Given this list of marker genes BCL10, RAB11FIP3, EXOC4, KASH5, BCL2L11, MARK4, KIF5B, NFS1, PQBP1, CEP76, HARBI1, TPGS1, CCDC15, TEKT1, KCNAB2, PIN4, CEP41, OVGP1, MARCKS, DNM3, SAXO4, CLMP, DLG1, EPS8L2, DCX (NCBI Gene Id 1641), HYLS1, RAB34, CFAP410, RIF1, DYNC1LI2, MICAL1, RPP25, TP53, GABRG3, CLIC4, EML5, MPHOSPH9, CALM3, PIK3R5, DYNLT5, KEAP1, HDAC3, DYNC1I2, LUZP1, PCM1, RPS6KA2, PACSIN2, NISCH, KIF2C, CDC7, FIRRM, REEP1, STRBP (NCBI Gene Id 55342), MAP1LC3C, TSKS, USP50, MVB12A, TUBGCP5, RASSF10, LRRK2, CEP78, PPP2CA, AK5, KIF11, GPSM2, DZIP1L, BMERB1, DUSP21, IPMK, DNAAF1, NFE2L2, TUBA8, CDC16, PDE4B, DCAF12, KAT2B, MAP7D3, SPRY2, GEM, TRAF3IP1, FAM184A, CCDC66 (NCBI Gene Id 285331), NPM1, TACC3, SMAD3, ZNF322, SNAP29, DYNC1LI1, PKHD1, TTBK1, CIMIP2C, PPP4R3B, NUDCD2, TTLL7, ATP2B4 (NCBI Gene Id 54594), AKNA, CFAP298, AXIN2, ANKS1B, FES, KATNB1, CHD3, RANBP9, CEP170B, CBX3, GNAI2, PIK3R4, TUBB3, RPS3, FNIP2, SORBS1, TAF1A, PJA2, CTNNBL1, EMD, MDM1, LRGUK, CHRM2, CEP57, RABL2B, DCTN2, LCK (LCK proto-oncogene, Src family tyrosine kinase, NCBI Gene Id 95387), TSC1, RITA1, KIF27, TNKS, HOXC8, PDCD6IP, ARHGEF10, TMEM67, KIF25, BOD1L2, RP2, CCDC141, AXDND1, EVC, MZT2A, FLCN, ZNF12, FNTA, NME8, TADA3, ABRAXAS2 (abraxas 2, BRISC complex subunit), DDHD2, CDC14A, PSMB5 (NCBI Gene Id 5693), TAOK1, NME3, CCDC13, SLC1A5, GAS2L3, CENPE, PLA2G6, CCDC61, DCLRE1B, PRKAR1A, CHMP1B, KIF3C, JADE1, MAPK1, NAV3, POLB (DNA polymerase beta), KIF26B, APC2, ALDOB, PBXIP1, CEP85L, CSPP1, INO80, NLRC3, TPPP, WASHC1, CDKN1B, PLK5, CCNO, PSEN2, ASAP1, RRAGD, AOX1, RIBC1, TERF1, FFAR4, RIBC2, CCDC57, MID1, CIAO1, DYNC2LI1, MIB1, LZTFL1, CCNE1, YTHDF2, TBC1D7, RABL6, DCTN6, BEX4, FCMR, CEP57L1, JTB, OFD1, TEX9, RASSF3, SDCCAG8, DZANK1, AGBL4, UHRF1, SELENOS, SLMAP (NCBI Gene Id 7871), HAUS1, CDC42BPG, KIF6, CEP126, CCT3, PRKCI, MIS12, SKA1, GTSE1, TEKT3, TBCCD1, STK3, RELL1, GLI2, UTRN, NUDC, UXT (ubiquitously expressed prefoldin like chaperone), PSMC4, GTF2F2, KIF18B (NCBI Gene Id 146909), CROCC, TFDP2, DNAH12, CD86, CTNND1, PLEKHA7, SAXO2, TTC28, PXN, RNF4 (NCBI Gene Id 6047), CD2AP, SERP1, FBXO5 (NCBI Gene Id 26271), CETN2, FAM234B, CAPG, MAPKAPK2, TPR, MKKS, HORMAD2, TUBB1, FMN2, BRCC3, IL4R, CCDC88C, CFAP95, CAMSAP2, CCT6A, PEA15, CROCC2, EZR, PDZD7 (NCBI Gene Id 79955), TOPORS, DVL1, RALBP1, ZFYVE19, CFAP107, ATXN7 (ataxin 7), GABARAPL1, FAM161A (NCBI Gene Id 84140), KIF21A, EML6, SPMIP6, CCND2, AGTPBP1, GPRC5C, CHMP1A, OCRL, TADA2A, MTUS1, CCDC178, CFAP100, SEPTIN10, MME, ASPM, SPDL1, SPMIP4, PRKAA1, KIF2B, HAUS8, SERINC5, AKAP11, TRIP4, WNK1, RAE1, UBR4, TRAPPC14, PARP3 (NCBI Gene Id 25908), TEDC1, BBLN, KATNIP, CCDC187, CFAP77, RANBP10, BOD1, MICALL1 (NCBI Gene Id 85377), CEP295, DYNC2I1, PPP4R4, CFAP20, EFCAB6, CCDC68, RIMBP3, IFT70B, ALMS1, PDZD2, PRKAR2A, RAB6D, PPP2R5A, TPX2, ZNF207, RTRAF, RAD18, PAX2, TTLL2, EIF3A, TOPBP1, HDAC6, ACLY, TRIM63, XRCC2 (NCBI Gene Id 7516), MAP6, WHAMM, OR2A4, RELB, TUBB2B, PLK2, TSGA10, RAB11FIP4, MATCAP1, KIF17, KIF5C, CEP68 (NCBI Gene Id 23177), PPP2R3C, MZT1, OLA1, KIF1A, CEP164, IFT22, BCAS2, WDR47, SPESP1, ZBED6, ZZZ3, NEIL2 (nei like DNA glycosylase 2), RACGAP1, GAS8, TTC23L, CLASP2, CABCOCO1, SEPTIN6, KLHL22, AHI1, SHROOM3, EFHC2, ZBED1, PSEN1, BCAS3, SARM1, EPB41L3, EML3, MAP2K5, STAG2, FIGN, NCAPD2, CDC45, CALML3, PROCR, IFT56, TTLL9, PHLPP2, CTDP1, SEPTIN1, BIRC5 (NCBI Gene Id 332), KAT5, LIMK2, DCUN1D5, KIF22, SPAG8, FBXW8, MT3, ESRRA, NAV1, TTC8, LRIF1, MYO18A, CHMP3, LEMD2, STAU1, HMBOX1, FBXL13, TTC39A, EEF1AKMT3, CUL7 (NCBI Gene Id 9820), RBM39, UVRAG, STMN1, CENATAC, TM9SF2, SFI1, THAP6, LRP8, ADH1B, RRP7A, CHRNA3, CCND1, HTT, CASP1, NLRC5, TTLL8, CIBAR1, TRIOBP, HIPK1, TUBA4A, TUBA3E, CEP70, MAK, ODAD1, IST1, CCDC117, CCDC112, DNAI2, TEKT4, DYRK1A, EFHC1, HMMR, SPMIP10, NIT2, PLAG1, PXK, UNC5CL, MAD2L1BP, DTX4, TOGARAM1, ACTR8, FBXL7, SIRT2, FANCE, PPP4R3A, CXCR2, KNCN, CCDC181, KLC1, RADIL, WDR13, TTBK2 (NCBI Gene Id 26044), ESPL1, H2AX, KPNA7, LRRC49, LRPPRC, RPGRIP1L, HOOK3, TBCA, CHMP4BP1, MAD2L2, SLC18A2, MDM2, AKAP9, ANKRD53, SEPTIN4, CFAP221, TMEM214, TACC2, SMAD4, CEP85, RB1 (RB transcriptional corepressor 1), TBATA, KRT18, CCND3, MAPT, PHF1, NSFL1C, RAC1, NPHP4, SPATC1L, DNAL4, CHAMP1, ACTR1A, TUBE1, CHMP6, DNAH9, DTNBP1, CCDC81, SEPTIN12, CIR1, PLEKHG6, SLC34A1, UNC119, CEP95, CHMP7, DNAJA1, KIF5A, WDR62, BICDL1, RGCC, IFT172, CTAG2, DNAAF5, AKT1, CEP20, BICD1, TEDC2, USP44, TENT5C, MARCHF7, SPAST, CFAP210, CEP120, ZNF415, KAT14, CDC42EP2, NINL, RIC8B, CIP2A, KIF24, SKP1, ORC2, PSMD10, GAPDH, CEP135, USP33, NIN, RSPH1, CAPN6, LATS1 (large tumor suppressor kinase 1), CKAP2L, TSG101, ARL2BP, MAD2L1, ARHGEF2, LRRCC1, HOOK2, E4F1, KIF19, PRC1, TPPP2, CEP83, DR1, EFHB, IQCD, KIFAP3, RAN, ATF5, DYNC2H1, SYBU, WDR35, CENPV, MYOF, NLRP3, HAUS7, SCYL1, RLBP1, PSRC1, MAP2, CDC14B, FRY (NCBI Gene Id 404759), DCTN1, DYNC2I2 (dynein 2 intermediate chain 2), USH2A, CAPN7, TPGS2, MCPH1, ARHGEF7, ARHGAP18, MYCBP2, DYNC1H1, SPMIP9, MAPKBP1, MFAP1, IFT122, SNCG, UMOD, ECT2, BRSK2, CCT5, PCGF5, NSUN2, HSPA2, IQGAP2, DCTN3, CCDC14, YPEL5, MAP2K1, ZNF397, DYNLT4, RGS14, TAPT1, NEIL1, PYCR3, ODF1, SEMA4D (semaphorin 4D), ADCY9, IFT57, LATS2, DIAPH1, B9D1, ANXA11, CEP250, TBC1D30, TUBG2, USH1G, CETN1, CDC27, PRKCA, CSNK1D (casein kinase 1 delta), NCBP2, TEKTL1, CCNJ, PARD6A, ALS2, MICAL3, DAPK3, ARL8B, IFT46 (intraflagellar transport 46), CEP43, IFT43, TBCD, CDK2, CEP19, CFAP276, TUBAL3, ZBTB49, BCL3, ARL13B, CRHBP, HSD3B2, PTK2, SPEF1, NCKAP5L, HSPA1B, ODAM, PPP1R12A, MLLT11 (NCBI Gene Id 149430), DYRK3, DYNLT1, SPECC1L, NME7, TUBA1B, REEP3, DNAH6, CADPS2, C11orf97, CCT8 (chaperonin containing TCP1 subunit 8), SAA1, FNTB, HYPK, MAP2K2, SPEF2, CEP112, CCDC170, STING1, CCDC88A, ZW10, KLF4, SPATC1, DNAH14, RAB11FIP5, B9D2, ALPK1, CSTPP1, DCTN4, NEK7, KIF14, RTTN, PSKH1, CCDC22, KLC2, IQCB1, DRD4, IQGAP1, MX1, PRPF19, CCDC103, PDIA6, CEP131 (centrosomal protein 131), NDN, GOLGA2, BCL2L10, LCA5, CPLANE2, PTP4A1, NEK6, CEP152, SEPTIN3, CCDC62, RAPGEF6, IL1RN, SVIL, CFAP157, MTCL1, KIF26A, DCDC2, EML1, CHEK1, INVS, CIMAP3, MDH1, FKBP6, RMDN1, TUBA1C, CDH23, DCDC2B, CDC42, RCC2, KIF3B, ROCK2, ANKRD45 (ankyrin repeat domain 45), KANK4, MAP4, CFAP126 (NCBI Gene Id 257177), TUBA3C, TTLL1, CALM2, CCDC18, IFT70A, DCTN5, CIMIP2B, HAP1, FKBP4, FAM110A, CNTRL, POLDIP2, RPGR, IFT88, SSNA1, SMG6, KLHL12 (NCBI Gene Id 59349), MYH10, CDK16 (cyclin dependent kinase 16), TSSK2, CEP89, HOOK1, FANK1, CDC42EP4, SMC6, KIF9, TRIM69, IFT27, WDR5, PBOV1, USP2, SYNJ1, CFAP90, C10orf90, BBS5, KIF21B, CFAP263, DST, LRP1, FRMD8, DYNLRB2, ZNF365, CCAR2, ATM, SEPTIN9, MAP10, PAK1, CCDC78 (coiled-coil domain containing 78), POC5, CNTROB, CAMSAP3, TEX35, CCHCR1, MMS19, KIF4B, KIF18A, BRAF, DBH, DNM1, GAS2L1, REEP4, HAUS3, MYH9, CEP290, SMAD6, CEP192, BBS9, GEN1 (GEN1 Holliday junction 5' flap endonuclease), CLTCL1, UBN1, HSPH1, HAUS5 (HAUS augmin like complex subunit 5), CAMK2B (calcium/calmodulin dependent protein kinase II beta), BORCS5, ARHGAP35, MKS1, ZNF330, PPP2CB, HRAS, GNAI3, TESK1, GRAMD2B, RILPL2, DCAF1, STK11, DNAI7, TEK (NCBI Gene Id 7437), LHCGR, DNHD1, CDC6 (NCBI Gene Id 990), MACF1, DCDC1, BNIP2, JAKMIP1, USP20, CCP110, MAPK3, ARL8A, SRA1, RILP, APPBP2, HERC2, CD180, SNAPIN, SMC3, NEK8, KLC4, PAFAH1B1, JPT1, TCP11L1, SKA2 (NCBI Gene Id 348235), ACAA2, POGZ, CEP97 (NCBI Gene Id 79598, centrosomal protein 97), NDC80, TUBB8, TUBB, LRRIQ1, TMEM201, PSMA1, ERC1, BUD31, RAD51D, USP9X, KAT2A, TRPV4, CLRN1, CBX1, ATP6V1D, ENKD1, FAM161B, BBOF1, CCDC85B, DNALI1, KATNAL1, RAB3IP, SNTB2, CHMP4A, SEPTIN14, HSPB1, DPP9, MAGI2, STAG1, CEP295NL, APC, PTPN7, CFAP58, MZT2B (NCBI Gene Id 80097), FGF13, IQCG, IFT20, CCDC65, NSL1, MEIG1, RBBP6 (RB binding protein 6, ubiquitin ligase), SASS6, STK33, MAPRE3, KNTC1, BRCA2, DNM1L, CREB1, CAPRIN2, BIRC7, TOGARAM2, SPAG6, SMC1A, DEUP1, ADH1A, WDR73, DNAH7, DENND1C, PIERCE2, KMT5B, RMDN2, CDK10, RASSF5, HASPIN, KIAA0586, TNKS2, TUBGCP6, LRWD1, CFAP161, TUBB2A, UPF3B, SPPL2B, TUBD1, BBS2, SMAD7, KLHL21, SPTBN5, TBL1XR1, CIB1, RPS7, CTTN, LSM14A, NUBP1, FSD1, GPR174, CSAG1, IVL, CCDC116, EML2, NUDCD3, ITSN2, DNAH11, MNS1, MAP7, DCXR, CUL3, TUBG1, CHD4, KIF12, CEP63, VIM, TTLL3, DNAH17, TRIM32, PMF1, TTLL13, PPP4R2, CFAP184, PIN1, CNP, SHROOM2, PPP1R42, AJUBA, PDE4DIP, ZMYND10, MAP6D1, EPB41, CCT4, TUBB4A, NUDT21, SPTAN1, ODF2, CCDC88B, CDH26, ODAD3, CCDC42, CFAP53, DYNLT2, PMM2, CEP44, TUBB6, CDK5RAP2, SHMT2, CEP55, DAAM1, NCKAP5, FEZ1, MAPK15, DNAI3, PYCARD, SPAG9, CHMP2B, RAB11A (NCBI Gene Id 8766), CDK2AP2, DDX3X, VPS4A (vacuolar protein sorting 4 homolog A), VHL, MAMLD1, EXOC7, CLUAP1, SAXO1, E2F1, MPP1, SPATA7, SPOUT1, BAG3, NEK9, CLIC5, SNPH, CFAP141, EVI5, RABGAP1, CFAP70, CCDC92, ATF3, FLOT1, NICN1, ECPAS, TBCE, KBTBD8 (kelch repeat and BTB domain containing 8), SSX2IP (SSX family member 2 interacting protein), PRKCQ, PSME3, CEP170, KIZ, MAP1S, IFT80, GAS2L2, TXNDC9, TBCC, SKA3, PKD2, NSMCE1, PINX1, SRPRB, RAB3D (RAB3D, member RAS oncogene family), GUCA1B, CDC20, ANAPC7, HSD3B1, RIMBP3B, AGBL2, RUSC1, CTNNB1, PPP2R1A, ZWILCH, MISP, IFT81, ATXN10, PPP1CC, WDR11, DYNLRB1, DNAH2, CIBAR2, BIRC6, NCOR1, GLI1 (NCBI Gene Id 2735), DLG5, HK2, TEKT5, PLK4, HECW2, UBXN6, TUBGCP3, BORA, TMEM9, DPYSL2, CKAP2, TTC12, TACC1, MAP3K11, DCAF13, WAPL, CFAP144, TEKT2, KATNBL1, DZIP1, KHDC3L, TCEA2, TAF1D, WASH3P, DYNLL2, DYNLT3, STIM1, HSPA6, ITGB1BP1, TUBB8B (NCBI Gene Id 260334), DNAH10 (NCBI Gene Id 55921), RMDN3, SHCBP1, CYTH4, NUAK1, CLTC, MLF1, ZFYVE26, VAPA, LRRC25, STOX1, AAMP, CLIP1, RAB6C, TAP1, TUBB4B, RAP1GAP2, MTUS2, KIF3A, CIAO2B, CCDC50 (coiled-coil domain containing 50), PRKACA (protein kinase cAMP-activated catalytic subunit alpha), TBCB, SLAIN2, EML4, PIBF1, CCT7, CEP162, SEPTIN7, APEX1, C2CD3, SEPTIN8, KIAA0753 (NCBI Gene Id 9851), TULP3, TRIM43, MAST2, SPIN1, FLII, MAP7D2, RAB28, SPAG5, IFT140, FAM110C, MARK1, CYLD, CDKL2, IFT74, WRAP73, CFAP45, NDRG1, DYNC1I1, NAA11, MAP1LC3B2, ADRB2, GSK3B, STARD9, PCNT, CRMP1, VCP, CILK1, GLG1, TTLL4, KIF2A, NGRN (NCBI Gene Id 51335), CHMP4C, TTLL6, IKBKG, VPS4B, NEK1, KIF15, MPLKIP, GLE1 (GLE1 RNA export mediator), CTSC, CCNA1, CHODL, CCDC28B, TGIF2, CCNE2, DAW1, AXIN1, TPT1, STX1B, ANAPC5 (anaphase promoting complex subunit 5), RANBP1, CHMP5, FHDC1, IRAG2, CDK5RAP3, TP73, USO1, AFG2B, CLASP1, DNAH1, POC1A, IK, ILK, POC1B, KLHL42, KATNA1, FER, TTC19, RAB8A, HAUS6, PLK3, CDC25B, PPP1R35, CEP128, NUSAP1, PKNOX2, CCDC102B, TRAT1, S100B, ABCC3, NR3C1, TSEN2, PKN2, SEPTIN11, RAB23, NEURL4, CFAP68, ACTR10, DYNLT2B (NCBI Gene Id 255758), ILRUN, BCCIP, KATNAL2, OBSL1, HID1, KIFC1, TBC1D31, CDKL5, WHRN, DCDC2C, KIF1C, BICD2, AAAS, SPMIP8, DLGAP5, BBS7, DNM2, GPX2, HSF1, SEPTIN5, STIL, SCTR, RILPL1, KNSTRN, KIF13A, DNAAF2, TEKTIP1, GABARAPL3, KIF4A, RNF19A (NCBI Gene Id 81036), SNX4, CSNK1A1, CDK5, CENPJ, PODXL, TMEM63A, SLF1, RASSF1, MECP2, PLK1, NEDD1, WRN, ARL6, MX2, PKP4, GNAI1, HNMT, ARFGEF2, OPA1, TMEM138, APOBR, RASSF7, MYC, CCNF, PRKACB, SHCBP1L, CCNB1, CIMAP1D, MAP1B, RAD21, IFT25, DISC1, CDK6, GRB2, CFAP96, SNX10, DYNLL1, SLC8A3, SLC25A5, DNAI4, SS18, ACTR1B, PSMB4, TBCK, ERCC6L2, INPPL1, ERCC2, RPGRIP1, DSN1, PIERCE1, RAB6B, AGBL1, CHMP4B, PRPF6, FBXW11, FTCD, HEPACAM2, TUBGCP2, KIF28P, MAP1LC3B, CCNA2, DIS3L, YES1, HSPA1A, AGBL5, TMUB1, ARHGAP4, PRKD3, HAUS2, BLOC1S2, CNTLN, CFAP206, LRRC45, SHROOM1, ARL3, SCLT1, NEK4, CCNB2, POLR3H, ARMC9, SAC3D1, FAM110B, FAM83D, DYSF, CCDC69, ACOT13, POLA2, TCP1, CCDC124, DIDO1, NEK2, SPECC1, RAB6A, SPICE1, REEP2, CFAP52, ROCK1, SBDS, CYP2A6, PPP4C, DTL, ATAT1, CCDC120, SFR1, PARP4, PCIF1, PCLAF, RIMBP3C, BRCA1, KIF20A, NEDD9, BBS4, RABEP2, DIAPH3, KIFC3, RUVBL2, SKI, ANKFN1, MAP9, NUP93, FBF1 (Fas binding factor 1), KIAA1671, PLA2G3, CKAP5, NUMA1, TTLL5, SLC16A1, TOP2A, ARHGAP6, AUNIP, UBXN2B, SPAG17, DNAH8, CCDC77, ANKRD7, SPMIP11, KIF23, AURKC, CCT2, CLIP4, DBT, EGFR, AURKA, CEP72, RRM1, STEEP1 (NCBI Gene Id 63932), NDE1, ADH1C, DNAI1, AKT3, RANGAP1, NUP85, ENKUR, TTK, DPF2, ABCA2, HOXB4, LEO1, CBY1, KIAA1217, KIF20B, CHMP2A, NAA40, INCENP, MAP7D1, RP1L1, VPS41, BAG2, PTPN20, CCDC8, ATP6V0D1, EYS, SHTN1, PRKAA2, STAU2, ARL2, SGF29, TRIM55, PCNA, PTPN23, RUVBL1, C2CD5, ENTR1, MAP1LC3A, MTA1, LZTS2, CALM1, MAEA, MAPRE1, DNAL1 (dynein axonemal light chain 1), MAPK14, VPS37A, INTU, RAPSN, CETN3, NUP62, DRC1 (NCBI Gene Id 92749), PACRG, CIMIP2A, KMT2E, KIF16B, BCL2L1, G6PD, ZNF804A, CCDC38, FZD6, SEPTIN2, TRAF5, TBL1X, HNRNPU, SPACA9, MBIP, EYA3, MAD1L1, TRIM54, KIFC2, CENPU, DNAH5, PROSER3, ANKRD26, CEP104, AURKB, IQSEC1, RPAP3, DDX11, CHP1, CCNJL, MASTL, CRACR2A, GABARAP, CCDC146, TMEM237, BUB1B, MAPRE2, TTLL12, MTCL2, TUBA4B, CEP350, IFT52, TTL, CDCA8, YEATS2, PRKAR2B, PATJ, KIF13B, CAMSAP1, NR0B1, RP1, ATF4, MFN2, DNAH3, MAP1A, MID2, TCHP, RAB24, CDC14C, MID1IP1, TUBGCP4, BRSK1 (BR serine/threonine kinase 1), CENPF, DHX9, MEFV, GPAA1, MCRS1, SLC1A4, CC2D1A, HNF4G, RAD51, KIF7, GIT1, KLC3, TTLL11, BBS1, TRIM75, KLHL4, WDR90, SLAIN1, PDE4D, AK6, ODF2L, SMO, SGO1, KLHL5, NDEL1, PRKCZ, AK9, KIF1B, BAIAP2, LYST (lysosomal trafficking regulator), CCSAP, CCSER2, CLTA, CDK1, CLIP2, ADCY10, CLIP3, TPPP3, TUBA1A, AGBL3, AFG2A, TUBA3D, NUBP2, HAUS4, MYF6, here is a description of the gene set: Human Gene Set: GOCC_MICROTUBULE_CYTOSKELETON studied in species Homo sapiens The part of the cytoskeleton (the internal framework of a cell) composed of microtubules and associated proteins.